The following is a description of a gene set: species: Homo sapiens The epithelial cell differentiation process in which a relatively unspecialized cell acquires specialized features of an acinar cell, a secretory cell that is grouped together with other cells of the same type to form grape-shaped clusters known as acini. Human Gene Set: GOBP_ACINAR_CELL_DIFFERENTIATION, and this is the list of marker genes: NR5A2, CLCN2, PROX1 (NCBI Gene Id 5629), CTNNB1, ZNF800